The following is a description of a gene set: species: Homo sapiens Human Gene Set: MIR7157_3P from publication Chen Y, Wang X (PMID 31504780) Genes predicted to be targets of miRBase v22 microRNA hsa-miR-7157-3p in miRDB v6.0 with MirTarget v4 prediction scores > 80 (high confidence targets)., and this is the list of marker genes: CA2, CLK3, BIVM, RAB7B, SLC1A4, NAT8L, ZFAND5, EGFR, CDC6, UPRT, ZNF704, FEM1A, ZNF160 (zinc finger protein 160), SPRED1, ADAMTS3, SCAI, GRIP1, POU2F1, CCDC32, MECP2, GSG1, FGF14, FAM78A, FGF12, CHMP2B, ZNF267, ELK4, DCAF10, OGT, SLC38A1, MARCHF4, CHD6, COL4A4, ZNF831, CXXC5, LMNB1, FKBP10, APLP2, SORCS1 (NCBI Gene Id 114815), WDR47, KLF9, TSPAN7, ARK2N, RAB8B, KCNQ4, SAMD12, TTC39C, LALBA, PCGF2, CLCN5, KLHDC10, PLEKHF2, SLC9A6, SLC35F1, DICER1, SCN4B, RAB5IF, TMEM187, TRARG1, EPB41L5, TULP3, DIDO1, SLC39A1, DDX5, MBNL1, CEP85L, LRIG1, MBD6, BBIP1, ZDHHC2, C11orf87 (chromosome 11 open reading frame 87), ACAD10, NRBP1, FOXN3, JCHAIN, PAN3, ZNF275, RICTOR, KCNF1, MAST4, AGL, SRCIN1, SLC1A2, SPIRE1, STK35, VIRMA, BCL3, NAMPT, BICD1, ZNF518A, PHF13, SKIL, PSME4, ALDH5A1, BCHE, GPAM, YEATS4, PCDH8, PDAP1, TAC1, AHRR, NCAM1, WDR3, PYHIN1, MMP24, PCDH17, DDX6, USF2, YY1, MED23, AP2A1, DYNC1I2, HIVEP3, TENM3, PACS1, RASSF5, MIER3 (NCBI Gene Id 166968), HECTD1, PLGRKT, ERRFI1, IER5, FGFRL1, SDC2, ATP10A (NCBI Gene Id 57194), STAU1, NUDT5, CELF5, FAM53A, MYLIP, ZNF33A, DDO, PALM2AKAP2, DPF1, C18orf63, LIFR, ATXN2, AS3MT, DTNA, ZDHHC11, FAM229A, RHBDL3, CNDP1, SLC11A2, UBN2, PUM2, GSK3B, RAD23B, KLF12, TLCD4, ZFHX3, SP4, ZZZ3, PHTF2, VPS13A (vacuolar protein sorting 13 homolog A), SLITRK6, C11orf58, MGAT4A, TUBG1, NRK, CADM2 (NCBI Gene Id 253559), ADCY5, TOP2B, COL6A5, MAT1A, EIF3H, ESAM, TIAL1, CARD17P, ETS2, TMEM132B (transmembrane protein 132B), APOB, MEA1 (male-enhanced antigen 1), ZMYND10, TMF1, PALLD, NKAPD1, TAB3, RIMS1, B3GAT1, WWP1, FHOD3, PECAM1, USP31, HEXIM1, CYP2U1, LIMCH1, CALN1, COA5, KANSL1, CEP350, POC1B, ANKRD44, TOX3, ACADSB, FIGNL1, FAM219A